Given this list of marker genes OTUD5, TTC21B (tetratricopeptide repeat domain 21B), RPL15, BHLHA9, CCDC22, MKKS, PLAA, ARMC9, PORCN, ACTB, BMPR1B, FGFR3, RPS15A, SC5D, PIGG, SF3B2, SMO, KIAA0753, C2CD3, DACT1, FANCE, VPS35L, PIBF1, RPS28, RPL31, DPYSL5, MAFB, GP1BB, ZNF141, CIBAR1, UFD1, PAH (NCBI Gene Id 5053), TOPORS, INTU, CEP290, LMBR1 (limb development membrane protein 1, NCBI Gene Id 85501), ARVCF (ARVCF delta catenin family member), MBTPS2, CSPP1, DYNC2I1 (NCBI Gene Id 55112), TBX3, BBS12, EVC, NSD2, RPS29, RPS20, RPL35, RPS27, CTBP1, RPL18, RAB23, CCDC28B, EBP, RREB1, NEK1, HEATR3, SUFU, ARL3, IFT27 (NCBI Gene Id 11020), ACOX1, CPLANE1, RPL26, CCND2, CHSY1, RPL5, GJA1, PRKACB, FGFRL1, SCNM1, WASHC5, GPC4, IFT140, RPS17, CEP104, TMEM231, ACTG1, RPL27, RPL8, RPS26, GJA8, GLI3, LHX3, ADA2, RPL35A, CHN1, DYNLT2B, PUF60, CEP41, FGF10, TCTN2, TMEM218, B9D1, NUP107, RNU4ATAC (NCBI Gene Id 57788), DEAF1, SALL1, FLII, ARL6, RPGRIP1L, DHCR7, ZSWIM6, SHMT2, EVC2, ARL13B, IFT74, PROP1, TMEM216, GLI1, LEMD3, RPL9, TSR2, GLI2, RPS19, GDF5, CPLX1, IQSEC2, CD96, FLNB, IFT172, UBE2T, PRKACA, GATA1, MAP3K20, RAB34, SEC24C, WDR35, IQCE, DYNC2LI1, BLM, FANCA, TFAP2A, DYNC2I2, CANT1, TOGARAM1, BBS2, INPP5E, LBR (NCBI Gene Id 653311, lamin B receptor), SALL4, PDE6D, LZTFL1, HESX1, PIK3CA, PIK3R2, PTEN, TMEM67, PPP2R3C, FANCB, TFAP2B, DYNC2H1, JMJD1C, NELFA, TBX5, WDPCP, RPS24, ZIC3, POU1F1, SETBP1, RPGRIP1, EFTUD2, ESCO2, DDX59, AHI1 (NCBI Gene Id 54806), AKT3, BBS1, EFNB1 (ephrin B1), NPHP1, TBX1, SHH, TCTN3, RAI1, CEP120, NAA10, WNT5A, RPL11, LETM1, TGFBR1, SMOC1, TMCO1, GJA5, TWIST1, TXNDC15, CBY1, KATNIP, CC2D2A, BBS9, FLI1, GPC3, DVL1, CHD7, ZNF699 (NCBI Gene Id 374879), TMEM237, OFD1, CDC45, HYLS1, ALX3, IFT80, COMT, TMEM107, MEGF8, B9D2, TP63, MKS1, TCTN1, WNT7A, BCOR, MAX, EXTL3, SH2B1, KIAA0825, RBM10, KIF7, ZNF423, FANCD2, HOXA13, FAM149B1, PNPLA6, ABCA12, FLNA, ROR2, WDR19 (WD repeat domain 19), HEPACAM, FANCC, TMEM138, HIRA, HOXD13, FGFR2, CFAP418, RPS7, LHX4, KIAA0586, RPS10, PHF8, here is a description of the gene set: Duplication of hand bones studied in species Homo sapiens Human Gene Set: HP_DUPLICATION_OF_HAND_BONES